The following is a description of a gene set: from publication Schaefer CF, Anthony K, Krupa S, Buchoff J, Day M, Hannay T, Buetow KH (PMID 18832364) p73 transcription factor network species: Homo sapiens Human Gene Set: PID_P73PATHWAY, and this is the list of marker genes: WWOX, RCHY1, FAS, MYC, SERPINE1, HEY2, AFP, BRCA2, FBXO45 (F-box protein 45), NEDD4L, GATA1, RACK1, ADA, TP73, TP53AIP1, FASN, GRAMD4, PEA15, PLK3, BBC3, CCNE2, DCP1B, JAG2, HAGH, KAT5 (NCBI Gene Id 10524), SP1, BIN1, PFDN5, MAPK11, SFN, PIN1, CCNB1, RAD51, PLPP1, YAP1, CDK2, NTRK1, FLOT2, CDK6, MDM2, TP63, EP300, PRKACB, WT1, IL1RAP, BCL2L11, BUB3, CDK1, TUBA1A, DEDD, SERPINA1, ITCH, ABL1, UBE4B, RELA, AEN, NSG1, NDUFS2, IL4R, GDF15, JAK1, SIRT1, BAX, RNF43, CLCA2, FOXO3, S100A2, MAPK14, PML, BUB1, CDKN1A, CASP2, BAK1, HSF1, TP53I3, CCNA2, RB1, CHEK1, PLK1